The following is a description of a gene set: Reactome Pathway: Reverse Transcription of HIV RNA part of: Early Phase of HIV Life Cycle species: Homo sapiens The RNA genome of HIV-1, like that of other retroviruses, is reverse-transcribed into double-stranded DNA, which is then integrated into a host cell chromosome and transcribed to yield both viral mRNAs and viral genomic RNAs. HIV-1 reverse transcription takes place in the cytosol of a newly infected host cell and involves multiple steps of RNA synthesis and degradation of the RNA strand of RNA:DNA duplexes mediated by the HIV-1 RT protein, as well as two template switches, to yield a DNA duplex colinear with the viral genomic RNA but with additional Long Terminal Repeat (LTR) sequence motifs at both ends.<p>HIV-1 RT has two catalytic activities essential for transcription of a DNA duplex copy of the viral genomic RNA: a reverse transcriptase activity and an RNase H activity. The reverse transcriptase is primer dependent and can transcribe both RNA and DNA templates in a 5'-3' direction. The RNaseH acts on the RNA strand of RNA:DNA duplexes and can catalyze both endo- and exonucleolytic cleavage of such an RNA strand. RT is a heterodimer of 66 and 51 kD polypeptides, both generated by cleavage of the HIV-1 Pol gene product: p66 contains Pol amino acid residues 599-1158; p51 contains residues 599-1038. Both active sites of the HIV-1 RT enzyme are contained in the p66 polypeptide, the polymerase activity in its aminoterminal region, and the RNase in its carboxyterminus. The p51 subunit lacks an RNaseH domain, and while its polymerase domain is intact, its conformation in the p66:p51 heterodimer occludes the active site.<p>The process of reverse transcription is outlined in the figure below: viral genomic RNA and primer tRNA are shown in black, "minus" strand DNA is shown in red, and "plus" strand DNA is shown in blue., and this is the list of marker genes: vpu, gag-pol, vpr, gag, PPIA, rev, vif